Given this list of marker genes Hdac6, Abca3, Zdhhc1, Isg15, Trim65, here is a description of the gene set: Mouse Gene Set: GOBP_POSITIVE_REGULATION_OF_PROTEIN_OLIGOMERIZATION Any process that activates or increases the frequency, rate or extent of protein oligomerization. species: Mus musculus